The following is a description of a gene set: Genes predicted to be targets of miRBase v22 microRNA hsa-miR-588 in miRDB v6.0 with MirTarget v4 prediction scores > 80 (high confidence targets). Human Gene Set: MIR588 species: Homo sapiens from publication Chen Y, Wang X (PMID 31504780), and this is the list of marker genes: COL4A4, MTMR4, XPO7, ARL15, SLC6A17, ST6GALNAC2, FBXW7 (NCBI Gene Id 55294), SLC31A1, TMEM233, RAP1B, SOX5, PGM5, NUAK2, ZNF716, GALNT15, TBC1D22B, TLCD3A, PSMD10, SPTLC2, XIRP2, MICAL3, NFAT5, DCLK1, ITIH4, PHF24, ZRANB1, RIMBP3, N4BP2, KLF7, MARK1, ING3, C1orf35, RHBDF1, XRCC2, CCND3, POGZ, DSTN, DGKK, JAM3, SEMA6D, MYPN, CNOT7, OTUD6B, CYB561, SHANK2, MTX3, DARS1, SHISA6, TIMP2, DOCK7, ZNF479, TGM6, MAP2, YWHAZ, LDAF1, SCN2A, UBE2D3, CENPN, STK26, PTPRO, CHST14, ATRNL1, KCNJ13, EMX2, GPR137C, POTEF, DDX3Y, SH3PXD2B (NCBI Gene Id 57517), SOX9, FAM227A, CERKL (NCBI Gene Id 394232), DDX3X, CLSTN2, CEP128, UBXN1, MGAT1, CCDC141, SET, AZI2, SDC3 (NCBI Gene Id 9672), TOP3A, NUP50, IQSEC2, NR3C1, FUT3, CLN5, TXNIP, DAAM2, ADAMTS6, DCAF7, ZFHX3, RIMBP3B, FZD5, ARNT2, SRSF6, RIMS1, RAB3B, TTPAL, UBE2H, HMGA2, KLHL14, TUSC1, MARCKSL1, SUCLG2, ROBO1, CTTNBP2NL, TNRC6C, KLHL32, RHOJ, HILPDA, TSHZ2, PAK5, ZNF704, RIMBP3C, TKTL2, CCDC92, B3GNTL1, ARHGEF15, RHOQ, PIGX, GDPD5, COL4A6, CUX1, PRKAR1A, GPC4, SATB1, NALCN